The following is a description of a gene set: Mouse Gene Set: REACTOME_SHC_MEDIATED_CASCADE_FGFR1 SHC-mediated cascade:FGFR1 species: Mus musculus, and this is the list of marker genes: Sos1, Fgf8, Kras, Fgf23, Fgf1, Fgf9, Fgf20, Fgf6, Fgf10, Grb2, Fgf17, Shc1, Fgf2, Fgf4, Hras, Fgf3, Kl, Fgfr1, Fgf5, Fgf22